Given this list of marker genes Cldn3, Pdgfb, Psg23, Pdgfa, F11, Serpine2, Sh2b3, Alox12, Clasp1, Pten, Thbs1, Phldb2, Fga, Wfdc1 (NCBI Gene Id 67866), Kng2, Mmrn1, Serping1, Plau, Plg, C1qtnf1, Anxa5, Prkcd, Serpine1, Adtrp, Thbd, Vtn, Ubash3b, Cd109, Ajap1, Eppk1, Tmx1, Tpsab1, F12, Gp1ba, Serpinf2, Tnf, Muc16, Fgf2, Kng1, Plat, Tspan8, Myoz1, Tmprss6, Plaur, Tfpi, Cask, Alox5, Pros1, Cd9, Smad3, Klkb1, Gp5, Proc (protein C), Anxa2, Slc12a2, Fgb, Ceacam1, Hrg, Prkg1, Crk, Apoe, Cpb2, Tafa5, Fgg, Cldn19, F2, Pdgfra, Clasp2, Adamts18, Wnt4, Apoh, here is a description of the gene set: studied in species Mus musculus Any process that decreases the rate, frequency, or extent of the series of events that restore integrity to a damaged tissue, following an injury. Mouse Gene Set: GOBP_NEGATIVE_REGULATION_OF_WOUND_HEALING